Given this list of marker genes Tbx20, Lin28b (lin-28 homolog B), Trpm3, Tmem45b (NCBI Gene Id 260382), Hs3st5, Nrg4, Pcdh19, Zbtb44, Lamp3, Phtf2, Yipf4, Gnpda2, Zfp423, Ap3s1, Larp1, Pkp4, Sh3tc2, Pde4dip, Gabpb1, Hps3, Nudt12, Phf2, Zmym2, Rab11fip1, Gabrq, Slc8a1, Cdc25a, Senp7, Rdh1, Tbc1d12, Zfp300, Slc6a18, Srsf1, Ccdc80, Or12j5, Zbtb25, Il3, Gspt1, Cyp3a13, Arih2, Rgs17, Usp16, Rtl4, Ktn1, Sec23ip, Mcts1, Tlr3, Atp1a1, Zfp488, Dgkb, here is a description of the gene set: Mouse Gene Set: MIR_3472 Genes predicted to be targets of miRBase v22 microRNA mmu_miR_3472 in miRDB v6.0 with MirTarget v4 prediction scores > 80 (high confidence targets). species: Mus musculus from publication Chen Y, Wang X (PMID 31504780)